The following is a description of a gene set: Hypoplasia of teeth Human Gene Set: HP_HYPOPLASIA_OF_TEETH Developmental hypoplasia of teeth. species: Homo sapiens, and this is the list of marker genes: EDA, RUNX2, RHOA, TGFA, NEK1, NF1, CTBP1, FLNA, MMP1, AXIN2, DNAJC21, FOSL2, ENPP1 (ectonucleotide pyrophosphatase/phosphodiesterase 1), GRHL2, RECQL4, LAMC2, FGFR1, GJA1, SLC10A7, LMX1B, IFT122, GNAS, SMCHD1, WNT10B (NCBI Gene Id 82499), MED12, LAMA3, AMELX, KRT14, IFT43, CYP2R1, GALNT3, OFD1 (OFD1 centriole and centriolar satellite protein), FGFR3, CLDN1, CARS1, GTF2H5, KIF7, OCRL, ITGA6, PCNT, ITGB6, ERCC3, CLDN16 (claudin 16), ACP4, GNB2, SEC23A, SMARCA2, MSX1, ZMPSTE24, RAP1B, VDR, LRP4, FGFR2, TP63, HLA-DQA1, SCUBE3, ERCC4 (ERCC excision repair 4, endonuclease catalytic subunit), AMBN, AIRE, SP6, PTDSS1, CYP27B1 (NCBI Gene Id 5135), RNF113A, C12orf57, TRIM37, EDARADD (EDAR associated via death domain), TARS1, ROGDI, CREBBP, HLA-DQB1, SUMO1 (small ubiquitin like modifier 1), IRX5, PGAP1, ERCC8, FLNB (NCBI Gene Id 8413), EP300, GTF2E2, PAX9, PCGF2, LONP1, KCNJ2, TTC7A, ODAPH, ERCC1, CTSK, COL7A1, HECTD4, WNT10A, CEP152, NECTIN4, PIK3C2A, SLC35A2, PEX1, STX16, UBR1 (NCBI Gene Id 64703), COL17A1, FAM20C (NCBI Gene Id 56975), FGF10, CSTB (NCBI Gene Id 1476), ERCC2, TRMT10A, LRP6, MPLKIP, FBXO28, PAK2, IRF6, PORCN, POLD3, SATB1, AARS1, ATR, IFIH1, LAMB3, COG6, ITGB4, SLC12A2, KRT5, NUP133, LMNA, DLX3, SMOC2, DDX59, CHD3, ALDH3A2 (NCBI Gene Id 224), EDAR, PPP1R15B, PLEC, ERCC6